The following is a description of a gene set: Mouse Gene Set: GOBP_POSITIVE_REGULATION_OF_PROTEIN_FOLDING Any process that activates or increases the frequency, rate or extent of protein folding. species: Mus musculus, and this is the list of marker genes: Grn, Pofut2, Pdia3, Pdia4, Hspa8